Given this list of marker genes MEDAG, PRRX2, CD44, KIAA0930, ACP5, MVP, TCF23, FABP3, ASRGL1, B3GNT7, ARSJ, HS3ST2, IFI16, ACKR1, MSANTD3, NGFR, PDIA5, PLEKHA4, BDKRB2, CDCP1, PTTG1, OLFM1, TNC, TTYH3, CD163, LHFPL2, TFPI, GPR137B, GAS7, PLCXD3, PTGFRN, MTHFD2, HPGDS, EMILIN2, CALHM2, PCSK1, VOPP1, CCL13, FLNC, IER5L, TNFRSF12A, SDS (serine dehydratase), IL10, ALCAM, COL8A2, ADGRL3, PDIA4, SERPINE1, TMEM119, HMOX1, SELP, OSMR, PRSS23, SCARA3, BEND6, FOSL1, LILRB4, ALDH1A3, MARCO, NT5E, MSR1, RPL13P5, GSTO1, PTTG1IP (NCBI Gene Id 756), TIAM1, TNFRSF11A, ADM5, COL14A1, SLC9B2, FPR3, PHLDA2, CXCL16, SERPINB8, MGP, TNFAIP8L3, PROS1, S1PR3, TAFA3, C3AR1, NIBAN2, NCS1, TMED3, MCUB, S100A4, CMKLR1, ST14, MCTP1, CILP, ELOVL7, BCAT1, SGMS2, TPM3, PHLDA1, ACTG1, DKK3, BACE2, CCL18, PRG4, ITGA5, NPM3, here is a description of the gene set: from publication Konigorski S, Janke J, Patone G, Bergmann MM, Lippert C, Hübner N, Kaaks R, Boeing H, Pischon T (PMID 35953519) Many studies have shown that abdominal adiposity is more strongly related to health risks than peripheral adiposity. However, the underlying pathways are still poorly understood. In this cross-sectional study using data from RNA-sequencing experiments and whole-body MRI scans of 200 participants in the EPIC-Potsdam cohort, our aim was to identify novel genes whose gene expression in subcutaneous adipose tissue has an effect on body fat mass (BFM) and body fat distribution (BFD). The analysis identified genes associated with adiposity, of which 531 encode a known protein and 487 are novel candidate genes for obesity. Enrichment analyses indicated that BFM-associated genes were characterized by their higher than expected involvement in cellular, regulatory and immune system processes, and BFD-associated genes by their involvement in cellular, metabolic, and regulatory processes. Mendelian Randomization analyses suggested that the gene expression of genes was causally related to BFM and BFD. Six genes were replicated in UK Biobank. Human Gene Set: KONIGORSKI_INCREASED_SUBCUTANEOUS_ADIPOSE_TISSUE_TOTAL_RATIO_DN Genes that exhibit a negative CJAMP (Copula-based joint analysis of multiple phenotypes) beta estimate (beta < 0) for association with subcutaneous-to-total adipose tissue ratio. species: Homo sapiens